Given this list of marker genes GLRA2, KCNQ1DN, PCSK2, DGKZ, AGT, AGRP, AKT1, DUSP4, A1BG, CHN2, RFFL, IL18BP, EGFL6, SLC26A9, MED24, FLT3LG, CCL5, SDHAF2, VAX1, ASPH, PLA2G3, DIS3L, CORT (NCBI Gene Id 1325), JADE2, NOA1, CYP26A1, LCP2, CPNE1, CCND2, ZNF546, ICAM1, HSD3B7, VGF, TCEA2, ZYX, GMPPB, CMTM2, STXBP6, APBA1, IRF4, IFT43, DBNDD2, MRPL24 (mitochondrial ribosomal protein L24), CCL2, TRIM25, OGG1, BATF, IPO11, SMPD3, GASAL1, MIR22HG, ATP11C, BCL9, ZNF233, IAPP, AP2S1 (NCBI Gene Id 9161), AMBN, MARCHF10, APOLD1, ARHGAP36, SLC38A5, NKG7, IL22, MYO18A, DGKA, IRF2BP1, PABIR3, OIT3 (oncoprotein induced transcript 3), DISP2, LSAMP (NCBI Gene Id 4045), LEP, PPARD, LAMA2, SOCS2, SLC50A1, TRIM46, NCALD, KLF4, CERT1 (ceramide transporter 1), PAN2, STEAP4, TET2, UGCG, SIGIRR, MIA2, KRTCAP2, ATP8A2, CREM, TRIM15, SLC30A7, USP25, ELMO1, ASCL3, TSKU, TEAD1, DDX17, PROK1, FRMD6, MECP2, NRP1, GFAP, ANKRD39, CXCR5, TNS2, FBXL9P, SYMPK, ZNF582, PI4KB, FGA, ATP5PD, PPBP, RLIM, SARM1, GPR21, FAP, TMLHE, TNFRSF9, KCNN3, ATXN7L2, HOXC5, ECEL1, EIF4E, FLT1, NME7, TNIP2, VASN, LIF, TMEM100, DLX4, SRPX, GPATCH4, TUT1, GPR153, VTN (vitronectin), POLR2B, CBLIF, KCNJ8, DOCK4, ARHGEF39, LTA, TNFSF11, LINC02915, AFF1, ADAMTSL3, ADAM11, TRPM7, IWS1, SDC1 (NCBI Gene Id 6382), BET1, CD40LG, GK, ING2, MAPK10, TEAD4, ANK3, COQ8B, PIK3R1, SEC24C (SEC24 homolog C, COPII coat complex component), NRXN3, PROX1, SMPD1, ARIH1, DTX2, RRAS, PVALB (NCBI Gene Id 5816), NT5C2, SYT12, UBR1, SLC1A5 (solute carrier family 1 member 5), TSHZ2, SEMA6D, CSN1S1, ETV5, RAB11B, THPO, GZMB, OLFML3, BTK, NOB1, BRINP3, CLDN8 (NCBI Gene Id 9073), CPSF7, C1QTNF1, CBL, MGAT4C, PHOX2B, VIP, ITPKC, RAP2A, TSPAN6, SCRG1, RBFOX1, TMUB2, PCDH1, HTRA2, LIN28A, CEP41, IRF8, IFT80, EXPH5, PMCH, CCDC25, HACE1 (NCBI Gene Id 57531), TMOD3, CFAP65, EXTL2, MAP2K3, NFATC4, SETD2, HOXA2, ZNF423, PPP2R3A, SMC4, GRB10, TMEM74B, CITED4, HOXA11, WNT10A, ADAMTS4, TAB2, POLR2M (NCBI Gene Id 81488), CLU, NOL4L, SERTAD3, CXCL11, DRC7, F9, PLEC, PROS1, LIN54, PSMD3, RBFOX2, ENPP2, HNRNPR, POU4F1, NR4A3, BDNF, MAFF, MIR17HG, PTPRO, KBTBD8, PLPP6, HJV, PALLD, CREBRF, RARA, STC1, HHATL, GSK3A, PCOLCE, HSF4, WDR81, ADAMTS9, NTF4, MXD1, GEN1, RBM14, SMC6, ZNF112, PTCHD4, RGS3, BCL6, PI4K2A, BCLAF1, TMEM95, TMEM163, HAMP, ELL, SBF2, ZNF180, TLR7, CLEC1B, PDLIM1, HOMER2, KCTD4, TLX2, BACH2, IFTAP, MASP2, RAB3B, MAP4K4, BTBD1, NUDCD1, NFIL3, C7, PHC1, CMTM6, POLK, AUP1, XRCC1, NEK6, PRDM1, RESF1, IGFALS, PHF21B, TMEM208, FN1, SLAMF1, TMEM60 (transmembrane protein 60), NDUFS2, PRKAR2B, ASXL1, SSBP4, MYL1, DLL4, BLZF1, CSF2, ARF3, ZNF235, CDH1, PALS2, IRF2, BIRC2 (baculoviral IAP repeat containing 2), CSN3, LINC00656, ABCC5, PLAGL1, IQCF2, OSM, MTTP, SPMIP6, LAMA1, OPRPN, CD247, LAPTM4B, SRPX2, PLSCR1 (NCBI Gene Id 5359), AP2M1, ADAMTS6, PPARGC1B, S100A3, LIX1, CISH, ADORA1, FOXA3, WIPF1, IRF9, SEPTIN9, EDEM2, TSPAN31, PPP1R9B, SERPING1, here is a description of the gene set: from publication Xie X, Lu J, Kulbokas EJ, Golub TR, Mootha V, Lindblad-Toh K, Lander ES, Kellis M (PMID 15735639) Comprehensive identification of all functional elements encoded in the human genome is a fundamental need in biomedical research. Here, we present a comparative analysis of the human, mouse, rat and dog genomes to create a systematic catalogue of common regulatory motifs in promoters and 3' untranslated regions (3' UTRs). The promoter analysis yields 174 candidate motifs, including most previously known transcription-factor binding sites and 105 new motifs. The 3'-UTR analysis yields 106 motifs likely to be involved in post-transcriptional regulation. Nearly one-half are associated with microRNAs (miRNAs), leading to the discovery of many new miRNA genes and their likely target genes. Our results suggest that previous estimates of the number of human miRNA genes were low, and that miRNAs regulate at least 20% of human genes. The overall results provide a systematic view of gene regulation in the human, which will be refined as additional mammalian genomes become available. Human Gene Set: TTCYNRGAA_STAT5B_01 Genes having at least one occurrence of the highly conserved motif M40 TTCYNRGAA in the regions spanning 4 kb centered on their transcription starting sites. This matches the STAT5B transcription factor binding site V$STAT5B_01 (v7.4 TRANSFAC). species: Homo sapiens